The following is a description of a gene set: from publication Chen Y, Wang X (PMID 31504780) studied in species Mus musculus Genes predicted to be targets of miRBase v22 microRNA mmu_miR_23a_3p, mmu_miR_23b_3p in miRDB v6.0 with MirTarget v4 prediction scores > 80 (high confidence targets). Mouse Gene Set: MIR_23A_3P_MIR_23B_3P, and this is the list of marker genes: Slc25a21, Csnk1g3, Radx, Lamp1, Tmem263, Trim68, Marcksl1, Kdm7a, Pkdcc, Slc38a1, Swt1, Zfp600, Rap2b, Clec4a2 (C-type lectin domain family 4, member a2), Mdfic, Trank1, Rora, Cnot6l, Fbxo9, Has2, Crlf3, Capn6, Rbm47, Satb1, Ctsq, Pax9, Ippk, Dnm3, Zfp654, Fbxo30, Thap2, Agap1, Vkorc1l1, Lclat1, Rex2, Rnpc3, Top2b, Hook3, Tent4b, Pde7a, Hoxd10, Calcrl, Cop1, Zfp839, Zfp85, Ubxn8, Hs6st2, Myh1, Ccm2, Morc4, Serinc5, Foxk1, Fut9, Lrrc2, Asah2, Pxdn, Tox3, Dgkb, Rer1, Il6ra, Chuk, Wdr37, Cxxc1, Bcl11a, Spsb4, Nrxn3, Yes1 (NCBI Gene Id 22612), Ctnnbip1 (NCBI Gene Id 93799), Hnf4g (NCBI Gene Id 30942), Ctcf, Tmem245, Robo2, Klf3, Cul3, A1cf, Sumf1, Snx27, Cblb, Zmym2, Sowahc, Ubn2, Ids, Ccdc158, Cep350, Zic1 (NCBI Gene Id 22771), Cldn12, Zfp354c, Slc4a7, Ppm1d, Zfp867, Erbin, Aldh1a2, Kdm6a, Tab3, Ndfip2, Atp11b, Tnpo1, Eif3a, Hexim1, Tmx1, Endou, Frat2, Tfpi2, Tlk1, Ep400, Blcap, Cdc40, Hdac9, Barhl1, Frem1, Mapre1, Caprin1, Strn4, Timm8b, Ppp1r3b, Atxn7 (ataxin 7), Zfp935, Sec23ip, Top1, Tent5a, Coa8, Arl8b, Cavin1, Adamts6, Fzd5, Car2, Gja1, Tmod1, Kcnk5, Nuak2, Ceacam5, Nrxn1, Acvr1c, Elf2 (E74-like factor 2), Hycc2, Zfp395 (zinc finger protein 395), Fastkd1, 3425401B19Rik, Chsy3, Espl1, Wee1, Pals1, Kmt5a, Naaladl2, Zdbf2, Cab39, Pknox1, Adamts5, Dhx15, Jarid2, Celf2, Cdk17, Ankrd33b, Pja2, Eif4enif1, Itsn1, Wnk1, Socs6, Gprc5b, Caps2, Dmtf1l, Fyb2, Safb, Nacc2 (nucleus accumbens associated 2, BEN and BTB (POZ) domain containing), Pak2, Ptger4, Mdfi, Rai14, Tgif1, Rras2, Elovl3, Nuak1, Rbm25, Mdga2 (NCBI Gene Id 320772), Ncoa1, Zbtb18, Foxp2, Rock2, Dcbld2, Cxcl12, Myh2, Tmed5, Ubap2, Nus1, Dip2c, Reps2, C1d, Nol4, Zfp579, Spock1, Met, Tbck, Zfp788, Aldh1l2, Akap12, Rab39b, Umad1, Gprin3, Lrig1 (leucine-rich repeats and immunoglobulin-like domains 1), Asb15, Esrp1, Pdia6, Tnrc6b, Adgrg2, Prkce, Prpf4b, Sorcs1, Sox6, Nek7, Myct1, Map3k5, Pcdh19, Sntg2, Tnks2, Snx5, Zcchc2, Retreg3, Map3k2, Ttc7b, Usp24, Slc4a4, Npy5r, Sft2d1, Slc18a2, Zbtb44, Rtf1, Pkia, Ppif, Tnrc6c, Nsd2, Etnk1, Sec24a, Pabpc4l, Casp7, Ssh2, Mbtd1, Ccng1, Adam23, Fbxo32, G3bp2, Endod1, Mettl16, Slc25a31, Srpk2, Pde4b (NCBI Gene Id 97194), Vti1b, Map4, Frmd5, Prdm1, Sms, Pou4f2, Gpr180, Arhgap20, Ccnl2, Rap1a, Slc1a1, Chst7, Grem2, Cep43, Nup50, Map3k15, Wnk3, Tbr1, Cpsf4, Naa16, Cdh17, Epg5, Rbpms2, Or51e2, Rad17, Bbip1 (NCBI Gene Id 75289), Auh, Ccdc47, Sema4b, Ipmk, Stam, Uqcrfs1, Ggnbp2, Ascc3, Tril, Tnrc6a, Jak1, Ebf3, Btaf1, Zfp292, Sap18, Maml2, Gls, Sesn2, Zfp1008, Kcnk3, Kdm1b, Ankrd26, Hoxb4, Atxn7l3b, Casd1, Myh4, Kdm4a, Lgr4, Sh3bgrl, Phactr2, Egr3, Ube2o, Vrk3 (vaccinia related kinase 3), Wbp4, Ube2d1, Inpp5a (inositol polyphosphate-5-phosphatase A), Tmem170b (NCBI Gene Id 669750), Pkp4, Gpsm1, Ntrk2, Zfp820 (NCBI Gene Id 75424), Senp6 (NCBI Gene Id 74825), Snrpc, Vcan, Asxl3, Mef2a, Zeb1, Camk2d, Gxylt1, Bora, Cggbp1, Pik3r3, Ptp4a2, Zc3h12c, Micu3, Hoxa3, Ccnt2, Dars2, Stk35 (NCBI Gene Id 67333), Mtf1, Rcn1, Zfp850, Slc7a1, Hmgb2, Cbll1, Cav2 (caveolin 2), Tnfaip6, Ppargc1a, Fam234b, Gng2, Acss1, Mat2a (NCBI Gene Id 232087, methionine adenosyltransferase 2A), Trib1, Usp5, Map3k1, Lhfpl2, Map3k21, Ssbp2, Nap1l5, Mab21l2, Col4a5, Nek6 (NIMA (never in mitosis gene a)-related expressed kinase 6), Tmem168, Pdxp, Lypla1, Slc6a14, Btla, Ncoa2, Pwwp2a, Stat5b, Hoxa11, Tmpo, Intu, Fut4, Xk, Fas, Lpar1, Bltp3b, Ormdl1, Exoc3l4, Cipc, Cpeb2, Lin28b, Magohb, Zfp597, Sec14l1, Prtg, Fosb, Elf5, Dock3, Tusc2 (NCBI Gene Id 93800), Lpp, Adamtsl3, Adgrl2, Gpr22, Wbp2, Ankhd1, Txndc16, Adam19, Mex3c, Zfp458, Meis2, Ppp4r4, Dnajc6, Zbtb16, Klhl13, Zbtb34, Map4k4, Kcnt2, Grm5, Mrc1, Trhr (thyrotropin releasing hormone receptor), Camta1, Nr6a1, Nin, Prr14l, Bbs7, Satb2, Bnip2, Prlr, Trps1, Ptk2b, Sema6d, Pbrm1, Zfp655 (zinc finger protein 655), Kbtbd8, C330018D20Rik, B3gnt5, Txnrd1, Tox, Zfp273, Asf1a, Six4, Rcn2, Fmr1, Ambra1, Thap12, Smurf2, Tgfbr3 (NCBI Gene Id 73753), Trmt10a, Hoxa1, Slc30a7 (solute carrier family 30 (zinc transporter), member 7), Stx12 (syntaxin 12), Entpd5, Zfp420, Gabra3, Trrap, Zfhx4, Zc3h13, Sec23a, Slc9c1, Tspyl5, Defb20, Cnn2, Klhl15, Stk4, Clec1a, Pde10a (phosphodiesterase 10A), Zfp874a, Serpinb8, Synj1, Tnfaip3, Cpsf6, Whamm, Gabra6 (NCBI Gene Id 14399), Ano4, Igsf8, Zwint, Zfp980, Vwa3a, Dcun1d1, N4bp1, 4930402K13Rik, Ppp2r5e, Pten, Pum2, Col4a1, Reep1, Serf1, Nufip2